The following is a description of a gene set: Any process that modulates the extent of synapse maturation, the process that organizes a synapse so that it attains its fully functional state. species: Homo sapiens Human Gene Set: GOBP_REGULATION_OF_SYNAPSE_MATURATION, and this is the list of marker genes: NRN1, ADGRB3, CAMK2B, YWHAZ, FGF7, NEFL, IGSF9, CNTNAP1, VPS35, NEUROD2, CDC20, CLSTN1, AGO2, SEMA7A, SNX27, NEURL1, DLGAP4, DAB1, FGF22, DISC1, DAB2IP, RELN, C1QL2, NFATC4, ANAPC2, ARHGEF15, NRXN1, ROCK1